The following is a description of a gene set: The process whose specific outcome is the progression of a cardiac atrium over time, from its formation to the mature structure. A cardiac atrium receives blood from a vein and pumps it to a cardiac ventricle. studied in species Mus musculus Mouse Gene Set: GOBP_CARDIAC_ATRIUM_DEVELOPMENT, and this is the list of marker genes: Tnnt2, Bmpr2, Hey2, Wnt5a, Dand5, Nphp3, Ccn1, Nkx2-5, Shox2 (NCBI Gene Id 352985), Eng, Bmp2, Wnt11, Bmp10, Nsd2, Nog, Mdm2, Pitx2, Sox4, Mesp1, Notch2 (NCBI Gene Id 99749), Gata4 (NCBI Gene Id 14463), Prox1, Sos1, Tgfb2, Notch1, Acvr1, Tbx5, Wnt2, Myh6, Mdm4, Heg1, Cfc1, Dll4, Ccm2l, Gja5, Smo, Zfpm1, Tbx20, Isl1, Ank2 (ankyrin 2, brain, NCBI Gene Id 99906)